Given this list of marker genes Lrif1, Pkd2l2, Caprin1, Zfp704, Spns2, Ubxn7 (UBX domain protein 7), Stx16, Azin1, G6pdx, Rnf139, Fign, Abhd3, Zfp473 (NCBI Gene Id 243963), Klf3, Acsl3, Dab2 (disabled 2, mitogen-responsive phosphoprotein), Macrod2, Arid1a, Pafah1b1, Ocrl, Vmn2r81 (vomeronasal 2, receptor 81), Dock5, Gpr153, Zbtb14, Ap1g1, Cfap58, Rims2, Coq2, Micos10, Lcorl, Med11, Akr1c14, Usp27x, Serpina3m, Cyria, Zdhhc7, Wdr4, Lrrc4c, Hook3, Slc25a22, Nus1, Ntrk3, Myod1, Ipo11, Zdhhc6, Nadk, Nfasc, Cobll1, Ndufaf7, Foxa1, Stk10, Insr, Rrm1, Tead1, Ankra2, Gpbp1, Syn1, Bach2, Tpp1, Mtbp, Nop10, Krtap9-20, Tbx20, Zfp609, Atrx, Zfp442, Gsdme, Cyp4v3, Pip4p1, Frk, Ccdc141, Wdr37, Tmem255a, Vdac3, Amot, Rsbn1l, Dmrt3, Cmklr1, Wnt11, Hdac1, Cers2, Runx1t1, Pcca (NCBI Gene Id 97921), Akap13, Ntpcr, Fli1, Hrob, Tmem59, here is a description of the gene set: species: Mus musculus Mouse Gene Set: MIR_3063_3P from publication Chen Y, Wang X (PMID 31504780) Genes predicted to be targets of miRBase v22 microRNA mmu_miR_3063_3p in miRDB v6.0 with MirTarget v4 prediction scores > 80 (high confidence targets).